The following is a description of a gene set: Human Gene Set: MIR6750_5P Genes predicted to be targets of miRBase v22 microRNA hsa-miR-6750-5p in miRDB v6.0 with MirTarget v4 prediction scores > 80 (high confidence targets). species: Homo sapiens from publication Chen Y, Wang X (PMID 31504780), and this is the list of marker genes: ANKH, ING5, STAM, HBB, TBC1D10B, CNNM4, PLD2, FBXO32, OSBPL7, THSD7A, DNAL1, REEP5, THUMPD1, TMCC2, ZNF510, COA6, ZSWIM6, PPIAL4D, PML, PFKFB2, GRIK2, USP54, SYNM, DPYSL3, GABRR1 (gamma-aminobutyric acid type A receptor subunit rho1), PPIAL4A (peptidylprolyl isomerase A like 4A), PDZD11, BCO2, RBM44, DLAT, SRSF3, NPTX2, DRP2, PEG3, C9, FUT9, FGF1, DUSP11, PPIAL4G, PPIAL4C, WWP1, SLC15A5, NFIC, AOPEP, MSL3, PPIAL4E, C1orf53, ANKIB1, UBQLN3, GALNT13, CYP7B1 (NCBI Gene Id 9420), LCP1, RAB39A, TENM4, CCR2, TSPYL6, ESYT1, DCAF8L1, TSC22D4, HMGXB4, TMEM243, TEX30, PPP4R3A, PTPN14, TMEM72, TRPV3, CREBRF, PPIAL4F, CPEB2, DCLK1, GLIS3, PEX3, RNF103, TAOK1, MKRN1